Given this list of marker genes Cga (glycoprotein hormones, alpha subunit), Hsd3b1, Hsd3b3, Hsd3b9, Hsd3b5, Srd5a1, Cyp17a1, Hsd3b6, Hsd3b2, Srd5a3, Hsd3b4, Lhb, Hsd17b12, Hsd17b3, Pomc, Hsd3b8, Srd5a2, here is a description of the gene set: Androgen biosynthesis studied in species Mus musculus Mouse Gene Set: REACTOME_ANDROGEN_BIOSYNTHESIS